The following is a description of a gene set: Human Gene Set: CREL_01 species: Homo sapiens Genes having at least one occurrence of the motif SGGRNTTTCC in the regions spanning 4 kb centered on their transcription starting sites. This matches the REL transcription factor binding site V$CREL_01 (v7.4 TRANSFAC)., and this is the list of marker genes: SMYD2 (SET and MYND domain containing 2), EIF5A, ACAN, TNFSF15, CHD4, TRIB2, BLCAP, RPS19, SLC30A3, ALG6, TACC1, ARHGEF2, STX19, KAT7, TLX3, SPTB, OLIG3, PAN2, S100A10, RPL23A, EHD1, UBE2H, TBC1D17 (NCBI Gene Id 79735), FAM117A, AMOTL1, TAFAZZIN, CLCN2, STC2, KRT36, CCM2L, EBF1, IGDCC3, PCSK2, COQ8B, E2F3, ZDHHC8, TP63, GNG4, ZDHHC24, TRIM47, MIDEAS, TNFRSF9, FOXS1, RAPH1, MIR17HG, BCL3, RASSF2, SH2B3, LRCH1, REL (REL proto-oncogene, NF-kB subunit), GNGT2, SIX4, RIN2, PPP1R13B, STX4, ARPC2, LAMA1, MSX1, TLX1 (T cell leukemia homeobox 1), SLC16A6, TP53, PURG, GPBP1, KCNN2, CLOCK (clock circadian regulator), FAM43B, FLOT1, MITF, S1PR2, NR2F2, NFAT5 (nuclear factor of activated T cells 5), BIRC3, CDC14A, PRDM12, ZNF593, CXCL11, SOX10, MAP4 (microtubule associated protein 4), ZBTB5, PTGES, TSNAXIP1, CYP2D6, YWHAZ, SOS1, FGF12, CALCOCO1, CYLD, IL13, ZFAND3, RELB, RAP2C (NCBI Gene Id 57826), RAB34, NXPH4, GRK5, DUSP6, COL11A2, STAT6, LINC01138, UBE2D3, GPM6A, MLLT11, RNF43, CSF2RB, PARP8, TRAF4, TCF7L2, ZEB1, MAP3K8, RFX5, HNRNPR, MOB3C, UPF2, IER5, CACNG3, TIAL1, NFKBIA, GADD45B, POGK, HCST, POU2F3, MAML2, VEZF1, RASGRP4, FTHL17, ACTN1, PNKD, UBD, ETV1, TNIP1, PCBP4, PRRT2, EHF, MAPK6, CLDN5, GREM1, TSLP, CYB5A, DOCK4 (NCBI Gene Id 9732), YWHAQ, KANSL1L, SDC4, HIVEP1, CHD6, TMEM88, CREB1, HGF, PCDH10, DDR1, MED13, GATA4, BMP2K (BMP2 inducible kinase), RPS6KA4, BCL6B, SOX5, CXCL10, HTR3B, PCDH12, AP1G2, CASKIN1, CD74, TUT1, SIN3A, NDUFB9, TSEN54 (tRNA splicing endonuclease subunit 54), TPM3, RBMS1, ENO3, CTDSPL2, LTB, ARHGAP5, DCLK1, CCL20, MIA, TFE3, FUT7, SLC6A12, NLK, CASKIN2, PLXNB1 (NCBI Gene Id 5364), GNAO1, SIX5, ELAVL4, FGF1, ITPKC, TATDN1, ZSCAN29, IL27, APPL1, EIF4A2, ABI3, APBA1, CCN2, SLC44A1, PIK3R3, IKZF3, ACTN3, KLK9, WRAP53, SMOC1, IL2RA, RRAS, ORAI1, CTDSP1, SLAMF8, IL1RAPL1, MLLT6, PFN1, RANBP10, CXCR5, MADCAM1, RIMS2, LRRC1, CD86, ICAM1, IL17C, IFNB1, SLC12A2, CD70, JAK3, CUEDC1, ZFHX3, SEC63, ZIC4, WNT10B, NFKB2, TNFSF18, TSPEAR, CDK6, WNT10A, AKT2, GDPD5, SOX3, TUBGCP4, MMP9, CNKSR1, COL16A1, CDC42SE1, WNT4, WRN, LIX1L, BAZ2B, KY, NFKBID, C1QL1 (complement C1q like 1), AKT1S1, EIF4G1 (eukaryotic translation initiation factor 4 gamma 1), CSF1R, TNFRSF1B, SMPD3, ERN1 (NCBI Gene Id 63433), MSC, CD69, CCDC107, TCEA2 (NCBI Gene Id 6919), G3BP1, IER3, CCL5 (NCBI Gene Id 8147)